Given this list of marker genes Cth, Mat1a, Txn2, Mpst, Ethe1, Ahcyl, Ahcy, Bhmt, Suox, Mtap, Cdo1, Mtrr, Tst, Mtr, Adi1, Cbs, Gadl1, Bhmt1b (NCBI Gene Id 329008), Ado, Enoph1, Mri1, Sqor, Fmo1, Bhmt2, Tstd1, Slc25a10, here is a description of the gene set: Sulfur amino acid metabolism Mouse Gene Set: REACTOME_SULFUR_AMINO_ACID_METABOLISM studied in species Mus musculus